Given this list of marker genes CD276, KIF1B, SERINC5, CNOT6, INSYN2A (inhibitory synaptic factor 2A), NXPH1, STOX2, CASD1, UNC5C, COL6A5, HSPA14, DDX3X, ZNF589, PPP1R14C, NCK2, BEND3, SHISA7, PCDH17, BACE1, DIPK2A, UBE3A, SOS1, ZNF480, CCDC50, SERINC1, FLCN, CHD1, TMEM119, PRTG, MRPL30, TLE3, CDK14 (cyclin dependent kinase 14), ALKBH1, PWWP3B, AKAP10, KBTBD2, KMT2A, PAFAH1B1, SEPTIN8, CIITA, PLEKHG7, GABARAPL1, ZNF689, C1S, CNDP1, DIS3, MAPRE1, ZFP90, PRCP, BCL2L11, LINC03040, RBM27, SERTAD4, LRRTM2, LHX6, NTRK2, KDM3B, SHC1, SLC15A2, PLEKHH1, RGL1, FAM219B, CGN, SORT1, SLC19A4P, WDR81 (WD repeat domain 81), CSF3, CASKIN2, SCARB2, KLF11, GLIPR1L2, MAN1A2, here is a description of the gene set: species: Homo sapiens Genes predicted to be targets of miRBase v22 microRNA hsa-miR-339-5p in miRDB v6.0 with MirTarget v4 prediction scores > 80 (high confidence targets). Human Gene Set: MIR339_5P from publication Chen Y, Wang X (PMID 31504780)